The following is a description of a gene set: studied in species Mus musculus Genes containing one or more binding sites for (Baz1a) in their promoter regions (TSS -1000,+100 bp) as identified by GTRD version 20.06 ChIP-seq harmonization. from publication Yevshin I, Sharipov R, Kolmykov S, Kondrakhin Y, Kolpakov F (PMID 30445619) Mouse Gene Set: BAZ1A_TARGET_GENES, and this is the list of marker genes: Etfbkmt, Pigg (NCBI Gene Id 433931), 2310022A10Rik, Hnrnpm, Snord43, mt-Ts2, Ddx5, Rtn4, Ypel2, Zfp988, Slc50a1, Wdfy1, Pet117, Mrpl48, Nsun2, Pde4d, 6430550D23Rik, Elac2, Snhg15, Cnot8, B9d1os, Ssh2, Tbccd1, Pes1, Plk2, Adk, Ccdc142os, Bmpr2, Mitd1, Zcchc4, Ndufa4, Itgb1bp1, Hspb3, Nadk2, Drg1, Dync1i2, Smarcal1, Nudt2, Upf2, Sh3bgr, Galnt10, Mettl23, Rbm48, Spata31e2, Gm17174, Rfc4, Heatr5b, Fam133b, Duxf4, Ezh2, Prdx1, Timm21, Arid4a, Gda, Ep400, Ercc8, Trim54, Sh3gl2, Thoc1, Klhl10, Septin2, Terf2, Blcap, Fgfr1op2, Srd5a1, Ganc, Sec31a, Gm8379, Dnajb11, Snrpa1, Cdin1, Proser3, mt-Nd1, Ppp4r3b, Zbtb18, Kat14, Slc25a38, Mau2, Rnpc3, Abcg2, Dyrk3, Pgap1, Rpl3, Tlcd3a, Mesd, Zfp24, B3galt4, Mir1938, Gm9996, Sdha, Cyp51, Cep44, Pex3, Pld3, Paxip1, Atad2b, Snx3, Wif1, Ubtd2, Smim12, Relb, Vps52, Ccz1, mt-Tn, Kmt5a, Gm8357, Sucla2, Ccdc92, Acer3, Tmem179, Ndufc2, Jmjd6, Acsl1, 2610005L07Rik, Ighv1-67, Ctnnb1, Ddx24, Hsp90aa1, mt-Tl1, Cpsf3, Kif24, U2surp, Ccdc127, Setd4, Armt1, mt-Th, Rhot1, Gpbp1l1, AI506816, Dctn6, Cfap68, Pcnx4, B230217C12Rik, Usp21, Hcn3, Xpot, Mrpl44, Rsbn1l, Mbd1, Lcmt2, Med23, Specc1, Trip4, Brap, Klhl6, Nxf1, Zpbp2, Ryk, Kif3a, Zfp354b, Ddx18, Snora9, Qser1, Caprin1, Tmem181b-ps, Tdrkh, Snx15, Eefsec, Ogg1, Smg8, 4930412F09Rik, Cltc, Inca1, Emsy, Tead1, Hspa1b, Zfp11, Bzw1, Pctp, Tm9sf2, Zfp174, Abhd16a, Zfp36l1-ps, Ifrd1, Gpalpp1, Smim14, Prr11, Nob1, Mapkbp1, Hspb6, Ppdpf, Limk2, Galk2, Mir6236, Ammecr1l, Cog4, Trip12, Pafah2, Mgst3, Ofd1, Derl2, Als2, Psen1, Sf3b6, Mrpl30, Tsga10, Ireb2, Gm13136, Arhgap23, Nploc4, Anapc16, B9d1, Nfu1, Skp1, Bod1, Mrpl42, Ssbp1, Mphosph9, Mdh1b, Tbc1d32, Rnf111, Gm15728, H2bc6 (NCBI Gene Id 328207), Sfi1, Gm42579, Zfp989, Gale, AU041133, Acad10, Man1a2, Tigd3, Perp, Eral1, Gm26868, Spata2, Sf3b3, Nt5c3b, Kif1c, Phf14, Acaca, Adal, Ank1, Heatr6, Grhl2, Zfp664, Srrm2, 1700040D17Rik, Acsf3, Polr2a, Nln, N4bp3, Rps18, Cops6, Phyhipl, Babam2, A430108G06Rik, Pbld2, Pik3c2b, Rpf1, Gm7008, Wtap, Atg3, Copg2, Rps6ka5, Cercam, Rb1cc1, Parp4, Gm13229, Coq4, Srek1ip1, Fancl, Ppa1, Cwc27, Cyp27a1, Ociad1 (NCBI Gene Id 68095), Ermp1, Zfp407, C130060C02Rik (RIKEN cDNA C130060C02 gene), Ormdl2, Spg11, Mir9769, Msh2, Gm13889, D230022J07Rik, Sec11a (SEC11 homolog A, signal peptidase complex subunit), Rnf24, Nufip1, Ptchd4, Pemt, Gm16136, Mrps23, Pkib, Gm12257, Nop14, Rab37, Lypd6, Nmt2, Ydjc, Tmem222, Wdr43, Duxf3, Cers6, Hdlbp, Tssk3, Afg3l1, Vti1b, mt-Tq, Mlh3, Cfap298, Ubr3, Cyth2, Myh10, Shprh, Dedd, Hectd2, mt-Tl2, Kctd13, Timeless, Bcl9, Hars2, Stam2, mt-Co2, Gng2 (guanine nucleotide binding protein (G protein), gamma 2), Sh2b3 (NCBI Gene Id 16923), Sugp1, A330041J22Rik, Rbks, Cul7, Adprhl1, Cant1, Faf1, Hars1, Fanci, mt-Ty, Slc22a15, Gm10222 (predicted gene 10222), Hnrnph3, Fntb, Dcaf7, Usp32, Clcn7, Mir1945, 6820431F20Rik, Gm22039, Epb41l4a, Dynlt1b, Cyb5r1, Dap, Ascc1 (NCBI Gene Id 69090), Mob1a, Slc9a3, Cherp, Zfp341 (zinc finger protein 341), mt-Tw (mitochondrially encoded tRNA tryptophan), Gm17232, H4c3, Smn1, Canx, Eif2ak1, Rfc5, 4930519P11Rik, Erich2, Sp3, Matr3, Slc39a11, Socs2, Gm13034, Eci1, mt-Tc, Ogdh (oxoglutarate (alpha-ketoglutarate) dehydrogenase (lipoamide)), Grk4, Ap3m1, Car7, Sh3gl3, Gm11398, Ppp1cb, Mtln, Ints13, Trappc2, Gm13223, 1700023H06Rik, Zfp850, 1700030C12Rik, Psmc3ip, Mphosph10, Zfp345, Hnrnpa2b1, Tm2d3, mt-Tv, Mir1904, Myo19, Rptor, Impa2, Srp68, Llph, Ube2d-ps (NCBI Gene Id 76508), Alad, Gar1, Rmnd1 (NCBI Gene Id 66084), Cbx3, Golga7, Gm15564, Rel, Gm5067, Ube2w, Fnbp1, Mrpl43, Asah1, Rps7, Gm25539, Med13, Prkca, Slc35a5, Gm14023, mt-Rnr2, 3110056K07Rik, Btbd9, Gm11735, A630052C17Rik, Endov, Nipsnap3b, Fam76b, Azin2, Hfm1, Dync2i2, Trub2, Gm43403, Ergic3, Thg1l, H3f3b, mt-Nd5, Mis12, Gspt1, mt-Td, Usp34, Ogfr, Mapkapk5, Mir7075, Mmab, Polr1f, Fdxacb1, Ecscr, Cndp2, Banp, Atp5f1a, Epn1, Twnk, Tmem87a, Lyrm2, 1810062O18Rik, Fscn1, Cox18, D930048N14Rik, Mrps22, A730036I17Rik, BC031181, Pigw, H1f4, Dus1l (NCBI Gene Id 97781), Zfyve27, Phf5a, Aco2, A330035P11Rik, Gm15559, Lmln, Eif2b2, Rprd2, Fastkd2, Frmd4b, mt-Ta, Tars2, Narf, Dimt1, Napepld, Fbrsl1, E2f3, Cep95, Tubg2, Duxf1, Yipf2, Hecw2, Fbxl20, Arih2, Nae1, Tmx2, Mtus1, Gm13687, Tmem94, Uba2, Mvk, Psmd12, Lrrc3, Gm11399, Ahsa2, Atn1, Wdtc1, Rpl21